Given this list of marker genes Amd1, Coq4, Hdc, Mlycd, Echdc1, Csad, Pck2, Urad, Gadl1, Uxs1, Acod1, Oaz1, Park7, Azin2, Odc1, Urod, Pck1, Mvd, Paics, Me3, Got1, Fahd1 (NCBI Gene Id 68636), Ddt, Me1, Pdxdc1, Azin1, Umps, Oaz2, Ldc1, Pisd, Acmsd, Gad2, Oaz3, Me2, Ggcx, Ppcdc, Ddc, Amd2, Gad1, here is a description of the gene set: studied in species Mus musculus Catalysis of the nonhydrolytic addition or removal of a carboxyl group to or from a compound. Mouse Gene Set: GOMF_CARBOXY_LYASE_ACTIVITY